The following is a description of a gene set: studied in species Mus musculus Genes predicted to be targets of miRBase v22 microRNA mmu_miR_3069_5p in miRDB v6.0 with MirTarget v4 prediction scores > 80 (high confidence targets). from publication Chen Y, Wang X (PMID 31504780) Mouse Gene Set: MIR_3069_5P, and this is the list of marker genes: Nsd1, Fyco1 (FYVE and coiled-coil domain containing 1), Vmn1r132 (NCBI Gene Id 667346), Creb3l2, Igfbp3, Eif2s2, Anks1, Ptpn2, Mmd, Cers2, Ppp2r3a, Oma1, Capn5 (calpain 5), Mcfd2, Asb1, Taf4b, Tm9sf3, Ccdc30, Phf19, Lyplal1, Scn2b, Cbfa2t3, Mctp1, Eea1, Fam167a (NCBI Gene Id 219148), Cdh9, Atoh1, Tgif2, Fam107a, Cbln4, Rock1, Htr2c, Krtap5-3, Pan3, Phc3, Ube2n, Nudt13, Fut9, Lpcat3, Tmx4, Hcn3, Per2, Trpc5, Hecw2, Cracdl, Psen1, Fat3, Slc25a44, Cdc25a, Slc25a35, Bcl2, Zfp689, Zfp966, Oxsr1, Stk26, Edaradd, Zfp967, Gnai2, Mindy2 (MINDY lysine 48 deubiquitinase 2), E2f5, Edar, Dmwd, Ldha, Phip, Cfl1, Ppp1r11, Osgin2, Dhx33, AB124611, Atg9a, Reck, Ndrg1, Hook3, Arid4a, Egf, Rras, Rgs8, Adam10, Itpr1, Slc35g2, Dcx, Sirt1, Nav1, Gnaq, Eml5, Onecut2, Dab2ip, Fam76a, Syt1, Frmd4a, Mta2, Vamp2, Zmynd11, Ppp1r1c (protein phosphatase 1, regulatory inhibitor subunit 1C), Akap11, Satb2, Abr, Mpp2, Sbspon, Zfp970 (zinc finger protein 970), Slc10a7, Megf10, Bcl11b, Abcd1, Vmn1r148, Epha4, P2ry2, Ube2w, Rnf128, Camta1 (NCBI Gene Id 75679), Jmjd1c, Camsap1, Stx17, Lrrc3, 2510009E07Rik, Yy1, Pkp4, Foxp2, Jade2, Unc13c, Emp1, Dipk2b, Gspt1, Astn1, Pdgfra, Fem1c, Snx4, Dixdc1, Cacna2d1 (calcium channel, voltage-dependent, alpha2/delta subunit 1), Car10, Usp24, Sinhcaf, Nectin1, Ppp1r12a, Eif5a2, Foxn2, Map3k20, Shkbp1, Tbl1xr1, Numbl, Kcnj2, Ppp1r9b, Olfm1, Bnc2, Has2, Casp2, Abtb3, Slc27a4, Gpr22, Pik3r3, Eif3j2, Galnt7, Rabgap1 (RAB GTPase activating protein 1), Ank3, Gpr165, Paip1, Zfp971, Pid1, Amotl2, Tmem167b, Fut8, H2bc6